The following is a description of a gene set: Mouse Gene Set: GOBP_INTERLEUKIN_18_PRODUCTION The appearance of interleukin-18 due to biosynthesis or secretion following a cellular stimulus, resulting in an increase in its intracellular or extracellular levels. studied in species Mus musculus, and this is the list of marker genes: Casp1 (NCBI Gene Id 12362), Gbp5, Nlrp3, Dhx9, Tlr9 (toll-like receptor 9), Tlr2, Tnf, Cd84, Nlrp6, Nlrp9b, Nod2, Usp50, Gsdmd